Given this list of marker genes Vps36, Vps25, Snf8, Ptpn23, Vps28, Stam, here is a description of the gene set: studied in species Mus musculus The process of directing proteins towards the vacuole that contributes to protein catabolism via the multivesicular body (MVB) pathway. Mouse Gene Set: GOBP_PROTEIN_TRANSPORT_TO_VACUOLE_INVOLVED_IN_UBIQUITIN_DEPENDENT_PROTEIN_CATABOLIC_PROCESS_VIA_THE_MULTIVESICULAR_BODY_SORTING_PATHWAY